The following is a description of a gene set: species: Homo sapiens Human Gene Set: chr19p12, and this is the list of marker genes: BNIP3P13, BRI3BPP1 (BRI3 binding protein pseudogene 1), VN1R81P, VN1R92P, CDC42EP3P1, BNIP3P26, ZNF429, ZNF209P, ZNF257, LINC01785, ZNF492, MTDHP4, ZNF826P, PCGF7P, VN1R83P, BNIP3P33, BNIP3P8, ZNF91, RPSA2, ZNF726, ZNF208, LINC01224, ZNF714, ZNF493, RPL7AP10, FIGLAP1, MTDHP3, ZNF849P, VN1R82P, MIR1270, RPL36AP51, ZNF254, LINC01858, ENSG00000268119, ZNF728, ZNF723, RPL34P34, BNIP3P47, ZNF93, ZNF708, RN7SL860P, GOLGA2P9, ZNF737, ZNF486, BNIP3P40, COX16P1, ZNF100, SNX6P1, ZNF676, BNIP3P25, VN1R88P, BNIP3P32, BNIP3P22, BNIP3P29, BNIP3P30, RNU6-1179P, ENSG00000260599, VN1R91P, VN1R84P, KRT18P40, BNIP3P38, VN1R78P (NCBI Gene Id 100312823), ZNF85 (zinc finger protein 85), ZNF99, ZNF724, LINC00664, VN1R85P, RPS27P29, CPSF6P1, BNIP3P16, BNIP3P34, ZNF730, ZNF43, RNA5SP469, RNA5-8SP4, ZNF430, BNIP3P35, VN1R87P, BNIP3P28 (BCL2 interacting protein 3 pseudogene 28), LINC03085, IPO5P1, ENSG00000269043, BNIP3P20, ZNF729, VN1R93P, BNIP3P31, MTDHP2, BNIP3P17 (NCBI Gene Id 100421704), CCNYL6, VN1R79P, VN1R90P, ZNF431, LINC01233 (long intergenic non-protein coding RNA 1233), BNIP3P15, ZNF675, ZNF682, RAD54L2P1, RPL34P33, ZNF725P, BNIP3P39, BNIP3P19, BNIP3P36, MTDHP5, BNIP3P24, BNIP3P27, ZNF90, LINC01859, ZNF98, ZNF626, ISCA1P7, ZNF66, ZNF681, ZNF738, ZNF92P2, ACTR2P2, VN1R80P, BNIP3P18, RPS8P11, BNIP3P23, BNIP3P37, BNIP3P14